Given this list of marker genes FBXO11, SPRED2, TEAD1, CNNM1, CDSN, SP7, SYP, SLC2A10, AK2 (NCBI Gene Id 83165), SCN3B, BTG1, EPHA4 (EPH receptor A4), GBP1, CYP1A2, JAM2, B3GNTL1, CASP14, DGAT2, GCNT3, FOXP4, ZCCHC9 (zinc finger CCHC-type containing 9), CCAR2, CTNNBIP1, NID1, UBAP2L, VAMP2, MARK2, FBRS, FBXL16, IL18RAP, LCE6A, CAPN8, ANKRD52, NOVA2, PXK, GPR162, GIGYF1, ZNF551, ASCC3, here is a description of the gene set: studied in species Homo sapiens Genes predicted to be targets of miRBase v22 microRNA hsa-miR-6782-5p in miRDB v6.0 with MirTarget v4 prediction scores > 80 (high confidence targets). from publication Chen Y, Wang X (PMID 31504780) Human Gene Set: MIR6782_5P